Given this list of marker genes Maff, Fgf15, Stc2, Bnip3, Ndufa4l2, Ccnd2, Mt1, Pfkp, Esrp1, Pdk1, Pfkfb3, Vegfa, Hk2, Tfrc, Tm2d2, here is a description of the gene set: from publication van de Sluis B, Muller P, Duran K, Chen A, Groot AJ, Klomp LW, Liu PP, Wijmenga C (PMID 17371845) Mouse Gene Set: VANDESLUIS_COMMD1_TARGETS_GROUP_2_UP COMMD1 (previously known as MURR1) belongs to a novel family of proteins termed the copper metabolism gene MURR1 domain (COMMD) family. The 10 COMMD family members are well conserved between vertebrates, but the functions of most of the COMMD proteins are unknown. We recently established that COMMD1 is associated with the hepatic copper overload disorder copper toxicosis in Bedlington terriers. Recent in vitro studies indicate that COMMD1 has multiple functions, including sodium transport and NF-kappaB signaling. To elucidate the function of Commd1 in vivo, we generated homozygous Commd1 null (Commd1(-/-)) mice. Commd1(-/-) embryos died in utero between 9.5 and 10.5 days postcoitum (dpc), their development was generally retarded, and placenta vascularization was absent. Microarray analysis identified transcriptional upregulation of hypoxia-inducible factor 1 (HIF-1) target genes in 9.5-dpc Commd1(-/-) embryos compared to normal embryos, a feature that was associated with increased Hif-1alpha stability. Consistent with these observations, COMMD1 physically associates with HIF-1alpha and inhibits HIF-1alpha stability and HIF-1 transactivation in vitro. Thus, this study identifies COMMD1 as a novel regulator of HIF-1 activity and shows that Commd1 deficiency in mice leads to embryonic lethality associated with dysregulated placenta vascularization. Genes up-regulated in 9.5 days post coitus (dpc) embryos with COMMD1 knockout compared to normal 8.5 dpc and 9.5 dpc embryos. species: Mus musculus